The following is a description of a gene set: part of: Caspase activation via Death Receptors in the presence of ligand species: Mus musculus This event has been computationally inferred from an event that has been demonstrated in another species.<p>The inference is based on the homology mapping from PANTHER. Briefly, reactions for which all involved PhysicalEntities (in input, output and catalyst) have a mapped orthologue/paralogue (for complexes at least 75% of components must have a mapping) are inferred to the other species. Reactome Pathway: Regulation by c-FLIP electronically inferred by orthology from the curated human pathway, and this is the list of marker genes: Casp8, Fasl, Tradd, Fas, Fadd